Given this list of marker genes CTCFL, KRTAP12-4 (keratin associated protein 12-4), SEZ6L (NCBI Gene Id 23544), SERPIND1, KRTAP13-2, TARDBP, KRTAP10-3 (NCBI Gene Id 386682), BCRP2, OR11H1, CLDN8, ANKRD20A11P, CLDN14, AP1B1, MCM3AP, FTCD, COL20A1, IGLC1, PCP4, MAP3K7CL, POTED, CHRNA4, APOBEC3B, PI4KAP2, ZNF280A, HUNK, CYP24A1, DNAJC5, LKAAEAR1, DIDO1, KRTAP13-1, PI4KA, APOBEC3A, DOK5, TMEM121B, TFF2, LINC01711, IL2RB, CLIC6, SOX10, MX1, here is a description of the gene set: NF-Y is a trimeric transcription factor containing H2A/H2B-like subunits, which specifically binds to the CCAAT box, a common eukaryotic promoter element. To gain insights into NF-Y-dependent transcriptional regulation, we assessed its relationships with positive histone marks by chromatin immunoprecipitation-on-chip and correlative-profiling studies. Unbiased identification of binding sites shows that the majority of genes are bound by NF-Y in the promoter and/or within the coding region. Parallel analysis of H3K9-14ac and H3K4me3 sites indicates that NF-Y loci can be divided in two distinct clusters: (i) a large cohort contains H3K9-14ac and H3K4me3 marks and correlates with expression and (ii) a sizeable group is devoid of these marks and is found on transcriptionally silent genes. Within this class, we find that NF-Y binding is associated with negative histone marks, such as H4K20me3 and H3K27me3. NF-Y removal by a dominant negative NF-YA leads to a decrease in the transcription of expressed genes associated with H3K4me3 and H3K9-14ac, while increasing the levels of many inactive genes. These data indicate that NF-Y is embedded in positive as well as in negative methyl histone marks, serving a dual function in transcriptional regulation, as an activator or as a repressor. from publication Ceribelli M, Dolfini D, Merico D, Gatta R, Viganò AM, Pavesi G, Mantovani R (PMID 18212061) Transcriptionally inactive genes whose promoters (regions between -2 kb to +0.5 kb relative to trascription start sites) where bound by NF-Y transcription factor. Human Gene Set: CERIBELLI_PROMOTERS_INACTIVE_AND_BOUND_BY_NFY studied in species Homo sapiens